The following is a description of a gene set: species: Homo sapiens Human Gene Set: HP_ABNORMAL_EAR_MORPHOLOGY Abnormal ear morphology Any structural anomaly of the ear., and this is the list of marker genes: DAW1, SEPTIN9, KIAA0586, DPH2, VPS53, CIT, CSPP1, PHIP, PIEZO1, FANCC (FA complementation group C), TCTN3, LONP1, TXNDC15, NOG, RSPRY1, TUBA1A (tubulin alpha 1a), GRHL3, NME5, SUPT16H, RAI1, GLRA2, RYR1 (ryanodine receptor 1), COLEC11, FLI1, NARS2 (asparaginyl-tRNA synthetase 2, mitochondrial), DCPS, TASP1, PDE6D, TENM3, GLI3, PTPN22, WDR35, CENPJ, ABHD5, NIPA1, NCF4, CAPRIN1, MGP, PROM1, KCNH1, WDR19, CTU2, EIF3F, GON7, TIMM8A (translocase of inner mitochondrial membrane 8A), GJB6, VSX1, TMEM147, JAG1, PLK4, GNB1, DPP6, STX1A, RMRP, RNASEH2B, TTI1, SMPD4, TOPORS, RPS23, KRIT1, KDM6A, GJB3, RDH11, CYBB, ALG6, ATP6V1B2, RBM10, GLIS3, MAX, KIF21A, GAS2L2, UHRF1, BRCA2, GAS8, KCNAB2, SYNGAP1, NKX2-1, KIAA0753, FOCAD, HSPG2, CDC45, MYH3, PDE6A, MPDZ, TMEM165, CERKL, ODAD4, ZMYM2, SMARCA4, MAN2B1, USB1, CEP55, MED27, MARS1, PIGS, SH2B1, ARID1B, CFAP298, ELANE, ADAMTS18, RPL5, TAP1, KATNIP, YWHAE, LRBA, NSUN6, TRAF7, VAC14, BSND, AIRE, HERC1, DSP, MSX1, TFAP2B, FGF20, DZIP1L, BBS12, PDCD1, H4C3, RIC1, SCARF2, XYLT2, POR, STT3A (STT3 oligosaccharyltransferase complex catalytic subunit A), TBCK, RIT1, AHR, SPIN4, NGLY1 (N-glycanase 1), PSMD12, ELN, PHGDH, SH3PXD2B, FTSJ1, FOXJ1, NDE1, RHOBTB2, DCLRE1C, SLC2A10, KIFBP, TAF1, ACTB (NCBI Gene Id 60), FIG4, B9D1, WWOX, TRIP11, DNAAF2, PDZD7, DDR2, TTN, USH1C, PIGY, PRDM16, SPEN, USH2A, CYP4F22, MRPS16, HNRNPK, INTS11, ARL13B, RPL35, MYOD1, TRIP13, MAB21L1, TMEM94, HECW2, DPYD, SLC32A1, IDS, DHCR24, CD81, PDPN, SPTBN1, NFKB2, CBLB (Cbl proto-oncogene B), EPG5, FOXL1, RPL18, B3GALNT2 (beta-1,3-N-acetylgalactosaminyltransferase 2), PDZD8, YRDC, DNAL1, RFWD3 (ring finger and WD repeat domain 3), TXNL4A, SNF8 (NCBI Gene Id 95670), EPAS1, ARX, PEX1, HDAC9, ZNF469, BBS2, GRB10, WLS, TGFBR1, PRKCD, GABRA3, PIGW, ZMYND11, DYRK1A, RIPPLY2, IMPG1, TALDO1, DEPDC5, PHF6, SETD5, NOTCH2NLC, ANK1, LIG4 (DNA ligase 4), RSPO2, CASP2, PLOD3, CTCF, ATR, NDST1, DPH1, UBA1, DNAI1, PHOX2B, FGF3, RAC1 (Rac family small GTPase 1), CRLF1, DNAAF1, ELMO2, SLC4A10, PCYT1A, DNAJC30, GLI2, TPP2, CPLANE1, SEMA4A, STK36, TCF4, COG7, TAFAZZIN, RSPH9, A2ML1, SMARCD2, EXTL3, KDM6B, KMT2B, MKS1, KCNK9, MCM5, GMNN, ACBD5, INSR (insulin receptor), RAG1, TMCO1, HEATR3, DDX6, CEP78, MGAT2, MBTPS2, EDNRA, SCLT1, SLC6A17, HLA-B, COL1A2, TOE1, ATIC, LMBRD2, KCNN3 (NCBI Gene Id 95947), AP1G1, TGM1, HCCS, NSD1, ORC4, SLC25A11, ASH1L, PIGK, CRELD1 (NCBI Gene Id 78987), RNF168, CHD7, SIX5, CCNQ, CHSY1, SYT2, PSMB8, ZSWIM6, SATB1, DHPS, CHD3, FBXO11, ZNF526, RET, SEC24C, ERF, BRD4, EGFR, FANCE, SLC7A14, LIPN, CENPF, GABRD, TRIO, SCN4A, CUL7, HMX1, SCNM1, CA4, EDEM3, CFAP300, SETBP1, SLC16A2, TBR1, GJB4, BPTF, KDSR, PPP1CB, FMR1, DNAI2, CHAMP1, SOST, MAFB, RAD51C, CD247, NCF2, IFT88, POLR1B, DCAF17, RUSC2, KLF13 (NCBI Gene Id 51621), GPKOW, PAX3, PYCR1, ZEB2, FSCN2, KIF11, BRAF, THOC1, ALG12, GTPBP2, SDHD, COG8, KIAA1549, FBXW11, AFF4, ZBTB20, IGHG2, DNAAF5, RAC2, TMEM138, CARMIL2, CBL, NALCN, HELLS, NPHP1, VPS35L, MUSK, PIK3CD, BTK, SLC37A4, BBS10, IGHM, TBX22, NEK2, SLC35C1, CASK, CCM2, DDX3X, SMAD2, CHUK, CSGALNACT1, POC1A, NFKB1, CLCF1, FANCD2, IFT56, CCDC103, SIAH1, RSPH1, TNFRSF13C, DPYSL5, RRAS2, PIGQ, RAB23, GUSB (glucuronidase beta), WDR37, DST, CEP290, GPT2, RPL9, KIF26A, NEXMIF, LMNA, STAMBP, RPL26, LRP5, BCOR, SKIC3, ECE1, DHCR7, FANCA, SLC25A12, SDHB, KAT8, PRTN3, B4GAT1, PDE6G, IL2RB, RAB11B, RPS24 (NCBI Gene Id 6229), IDUA, ACTG2, CCDC39, CDCA7, RPL31, TRPS1, CXCR4 (C-X-C motif chemokine receptor 4), ZNF668, RUNX2, TRPV6, NRCAM (NCBI Gene Id 4897), SOX9, HLA-DPA1, KCNJ10, FANCM, IDH3B, SEMA3E, MAD2L2, FRMPD4, UNC119, LBR, SH3KBP1, FOXP1, PRKCZ, PRORP, SPOP, FREM2, OCLN, LARGE1, ACAN, ABCA4, ORC1, RECQL, B3GALT6, DEAF1, ZNF513, TBCE, RARB, CSNK2A1, SPEF2, DRC1, AGA, FBN2, GAD1, POMT2, POMGNT1, AGPAT2, DNAH11, RERE, PI4KB, ANAPC7, RALGAPA1, PIK3CG, LRP2, VIPAS39, MAGT1, NR4A2, ITGA8, SRCAP, GATA1, EXOSC9, CEP295, H4C9, COL4A6, ACVR1, DOCK6, CDHR1, SPINT2, SPATA7, ANKRD11, LMX1B, EZH2, DLX5, HLA-DRB1, PLEC, OTUD7A, PAK3, TUB, AP1S2 (NCBI Gene Id 8905), RAB3GAP1, INPPL1, PLAG1, TMEM216, GDF11, SMOC1, TUBB, SLC6A8, MASP1, TPM2, ADGRG6 (adhesion G protein-coupled receptor G6), TRAC, KIF1B, MS4A1, SLC26A2 (solute carrier family 26 member 2), GUCA1B, UBE2T, PEX3, GNS, ZC4H2, SUOX, TUBGCP6, HDAC4, MAGEL2, OGT, ITGB4, SET, PSMC3, COCH (cochlin), ADAMTSL1, KLHL40, TRMT1, CDK13, AKT1, NR2E3, CCNO, UBA2, RPS27, CCDC65, SMC3, GRIA4, PEX10, PRKDC, CACNA1C, SIX2, FGFR1, SPART, FZD2, RFXAP, PORCN, UPF3B, ROR2, ADAMTSL2, CNOT2, TMEM70 (NCBI Gene Id 54968), ACOX1, CUX1 (cut like homeobox 1), FRMD4A, CFAP418, SBDS, EBF3, DOCK8, USP7, NEK9, TTC8, GREB1L, FRA10AC1 (NCBI Gene Id 57208), CCBE1, ETFA, BBS7, P4HA2, PCLO, ORC6, TP63, ARMC9, GNE, ITGA3, RPS15A, BLNK, TNFSF12, KDM5C, UBE3B, PREPL, ATP2B1, MCTP2, PPP1R15B (protein phosphatase 1 regulatory subunit 15B), MAK, UNC80, VPS37A, SDR9C7, MTHFR, AMMECR1, ALG13, MACF1, BMP1, IL21R, MRPS22, COL4A1, PNPLA6, TAF6, C1GALT1C1, HS6ST2, ATP6V1E1, ASCC3, SLC5A7, HYMAI, CAMKMT, NME8, POLR1D, DVL1, KCNQ1, KAT6A, BRCA1, ADAM17, NAA60, PRR12, BRIP1, MYO7A, ABCC1, HEPHL1, ALG9, RAB3GAP2, WAS, UBAP2L, PPM1B, HBA1, PRPS1, FCGR3A, PEX5, CD79B, JMJD1C, WAC, AGO2, ZNF423, EYA1, DIS3L2 (NCBI Gene Id 282696), BEST1, TBX15, POGZ, NOTCH2, CHRNG, TGDS, IRF6, WNT9B, WDR26, ANKH, CD79A, BMP4, PEX12, IMPDH1, BICRA, PRDM5, ANO1, KDM5A, SUZ12, ACP5, TBX4, RPS28, UMPS, SMC1A, DLK1, CD3G (NCBI Gene Id 917), RBM8A, STAG1, FOXP2, ETFDH, ESAM, MRPS2, MPLKIP, IDH1, AGBL5, POLR3A, PKHD1, CARS1, GJA1, DLG1, IGKC, PEX13, BBS1 (NCBI Gene Id 79702), ADA, HES7, EFEMP1, ARSG, MARS2, PRPF31, HDAC6, HS2ST1, RPS6KA3, RBP3, ZMYM3, EXT2, PSAT1, RPS29, RNU7-1, GTF2H5, PRKG2, CFAP221, KATNB1, RSPH4A, FOXF1, RP1L1 (RP1 like 1), NEB, APC2, PEX11B, PIGG, CDT1, DNAH9, MAD1L1, SOX6, PGM3, SLC1A4, ACTG1, SIN3A, EVC2, KCTD1, SULT2B1, MRAS, DHX16, TMEM237, CTH, PLAAT3, TWIST1, RPGR, FAM20C, MYO18B, PIGH, GLUL, IFT172, FAT4, AGRN, FBN1, DOCK2, CLCNKA, TMEM127, PRCD, POU4F1, STAC3, CPLX1, TNPO2, PDE6B, PIK3C2A, BMP2, CLTC, HSD17B4, GTF2IRD1, PLVAP, SGMS2, METTL27, CC2D2A, LIG1, KCNJ2, KDM5B, CCDC8, TBL2, RTL1, SPI1, RNASEH2A, EXOSC2, DHDDS, COL11A2, BRCC3, TNFRSF11A, B9D2, DACT1, IFIH1, H3-3A, SETD2, PTDSS1, RFXANK, VPS13B, CLCNKB, PLAGL1, TNNI2, RB1, RBBP8, ZBTB18, TLK2, SDHAF2, UBB, H4C5, SRRM2, NF2, IDH3A, RASA2, NEU1, CDK10, DBR1, LMBRD1, PPP2R5D, TTC12 (tetratricopeptide repeat domain 12), BICD2, TUBB3, SOX4, ODC1, CNGB1, SEMA5A, DOCK7, LRP4, CNOT3, RP9, JARID2, GJB2, BIN1, GJA8, TMEM260, INTS1, FKTN, CTNND1, RPGRIP1, SHOC2 (SHOC2 leucine rich repeat scaffold protein), RPS26, HUWE1, RAPSN, TCTN2, ZNHIT3, CAV1, SYK, RSPH3, BBS5 (NCBI Gene Id 428), CILK1, FUCA1, ODAD2, TBC1D20, PIBF1, CCDC50, MMP23B, NFIA, PUS7, LMNB1, NTNG2, TP73, OTUD6B (OTU deubiquitinase 6B), CLCN7, ALOX12B, TCF3, CDK5RAP2, PCDH15 (NCBI Gene Id 7397), UBR7 (NCBI Gene Id 55148), POLR1C, MAP3K7, RPS19, COBLL1, ICOSLG, CCDC22, NUP85, LETM1, ATP6AP2, ADAMTS15, STIM1, MLXIPL, PTEN, PPP1R12A, PCARE, YY1, MID2, LZTR1, ERCC1, QRICH1 (glutamine rich 1), SAMHD1, CDC42BPB, ACER3, SP7, OSGEP, COMT, PHACTR1 (NCBI Gene Id 81705), PLOD1, CFAP74, WARS2, PLAA, SF3B2, PLXNA1, RAB34, IL7R, COQ6, RREB1, NR2F1, TFAP2A, PEX2, CHMP1A, SCO2, YME1L1, RAP1B, CAMK2G, FKBP6, TRAPPC9, ELMOD3, EIF4H, SPECC1L, OTOF, PALB2 (NCBI Gene Id 79728), DHX38 (DEAH-box helicase 38), SALL1, GPX4, KMT2C, RRAS, TUBG1, MED25, PSMB10, DOK7, MYO9A, PGAP3 (post-GPI attachment to proteins phospholipase 3), PPP2R3C, FBLN5, SF3B4, CCDC47, RGR, DYNC2LI1, ESCO2, KIF14, FANCF, SMAD4, ROM1, HLA-DPB1, AARS1, COL2A1, MEGF8, IGF2, MEIS2, SHANK3, APC, FAR1, PAK1 (NCBI Gene Id 5058), SETD1A, SALL4, PAICS, NF1, ODAD1, CREBBP, GLE1, WIPF1, EFTUD2, LRPPRC, IL17RA, RELB, FKBP14, DENND5A, NAA10, RAF1, PCNT, AMPD2, TRRAP, FN1, RPS10, PNP, RELN, SLX4, ICOS, ARL2BP, MSX2, FANCG, IGBP1, TBC1D24, TUBGCP2, ATP6V0A2, BAZ1B, WNT3, TCOF1, CLRN1, MRPS14, CD3D, CEP120, GPC4 (NCBI Gene Id 2239), PLCH1, SON, PIK3R1, ODAD3, GDF6, MAP2K1, NIPBL, DNMT3A, ERCC5, PIGL, AGO1, TAPT1, CLIC2, PRPF6, MAP2K2, SATB2, TNFSF11, IKBKB, JUP, TNNT3, PUF60, NSDHL, RPL11, IL6ST, DNA2 (DNA replication helicase/nuclease 2), CD3E, CYBA, SSR4, G6PC3, MESP2, ABCC8, COL13A1, ESRP1, ERMARD, STRA6, TREX1, CEP57, DNAAF3, TBC1D23, CHD4, RLBP1, RNF2, VARS1 (valyl-tRNA synthetase 1), OPHN1, MVK, SDHC, CR2, PRRX1, MERTK (NCBI Gene Id 10461), THOC2, DNAAF4, ANTXR2, HGSNAT, JAK3, ARID2, AHDC1 (NCBI Gene Id 27245), POLE, SOS1, ZBTB24, SHARPIN, THRB (thyroid hormone receptor beta), TLR8, GNAI3, SIX1, U2AF2, WNK3, GLB1, SLC39A7, ASXL1, EXT1, ERCC8, PRPH2, FAM161A, GSC, TCF20, RTTN, LARP7 (La ribonucleoprotein 7, transcriptional regulator), USH1G, TBCD, TMEM231, POU3F3, SNAP29, RXYLT1, KMT2D, FDFT1, ATRX, LIFR, EXOC7, DNM1, SNAP25 (synaptosome associated protein 25), PDCD10, C2CD3, MEF2C, RPGRIP1L, GATA4, KIF15, MRPS28, VPS51, SNRNP200, EFEMP2, TOGARAM1, NANS, LAGE3, PLXND1, CACNA1B, OCRL, KDM4B (lysine demethylase 4B), PTPRF (protein tyrosine phosphatase receptor type F), CHD8 (chromodomain helicase DNA binding protein 8), TMEM270, TRIP12, ALX4, CEBPE, HHAT, THUMPD1, PLCG2, ITGB6, VHL, B4GALT7, PEX6, HMGA2, CDH2, MESD, CHST14, PRPF4, SCAPER, PIK3CA, SMCHD1, ERI1, SLC6A9, CHD5, ZMPSTE24, KAT6B, LSS, TBX2, KCNJ5, HARS1, AMER1, RDH12, CACNA2D1, UQCRH, KIZ, NHS, MECP2 (NCBI Gene Id 8274), VPS33B, CTBP1, TRAIP, MBD5, WARS1, AEBP1, FREM1, SAG, SLF2, MN1, KDM3B, CPE, AK2, CASZ1, GRIP1, DIAPH3 (diaphanous related formin 3), PUM1, CHRNA1, PGAP1, PAX1, DNAH1, TFE3, CDH11, HAX1, FOXI3, ARL3, TNRC6B, PITX1, AIP, ZNF699, NIPAL4, MRTFA, NUP188, SPAG1, WHRN, CIITA, CEP19, KLHL7, MSL3 (MSL complex subunit 3), SLC9A6, ROBO1, COX7B, HYAL1, ENPP1 (NCBI Gene Id 5167), CDKN1C, ZNF462, ATP6V1A, BSCL2, PIGU, NFKBIA (NCBI Gene Id 4792), PTF1A, EHMT1, BCL11A, RAD51, WNT4, IRX5, GPR101, SLC12A6, HAAO, EVC, MYSM1 (Myb like, SWIRM and MPN domains 1), TPRKB, TCTN1, DAG1, DNAJC21, USP26, IFT81, TTC5, HGD, ALX3, ZNF148, NFIX, SEC61A1, PCGF2, FGF9, B4GALT1, OSTM1, IFT52, ZFX, ATRIP, POLA1, IFT74, HRAS, ZMIZ1, SLC39A8, IREB2, LZTFL1, FBXW7, CAPN15 (calpain 15), NUP107, FH, IGLL1, FOXE1, RAG2, ARVCF, IGF1R, MCIDAS, CEP104, BUB1B, PIGO, AASS, ALMS1, ZDHHC9, ALDH1A2, NEK10, KNSTRN, HBA2, RFX5, C4B, NUP133, GRIA3, MED12, IPO8, SLC18A3, ERCC4, CLCN3 (NCBI Gene Id 133073), CTSD, FKRP, OTX2, WDR4, ESRRB, ADGRV1, CHRNA7, FRAS1, CDH23, IL2RG (NCBI Gene Id 3561), ARHGEF18, HOXA13, COL6A1, CTNND2, RAD21, BCL11B, STEEP1, ACTA1, WNT7A, TMEM67, CRB1, WBP11, RNASEH2C, PEPD, LFNG, ADAMTS3, STAT3 (signal transducer and activator of transcription 3), IFT140, BBS9, GFRA1, MDH2, WDPCP, PEX16, NRL, HIRA, TEFM, PIGV, NEK1, TCIRG1, CPOX, NECTIN1, DSE, SLC25A1, WDR73, SOD1, NKAP, CYBC1, KIF7, ALG2, SLC2A1, ADAR, IMPG2, CRPPA, DNAH5 (NCBI Gene Id 64774), ALDH18A1, UGP2, TP53RK, PQBP1, DPF2, FANCI, TTI2, SMS, RPL10, CENPE, PRKAR1B, AIFM1, LUZP1 (leucine zipper protein 1), WNT7B, MKKS, DHX37, CORO1A, PGAP2, ASXL2, KCNJ11, PEX14, RNU4-2, NIN, CCDC40, REEP6, TUBGCP4, ASPRV1, RPS7, CNTNAP2, ITGA6, DVL3, PBX1, COG5, PRPF8, TET3 (tet methylcytosine dioxygenase 3), C1QB, PAM16, FOXL2, ANAPC1, NARS1, HSPA9, AGR2, KMT5B, BBIP1, MMACHC, ASNS, MPDU1, RIPK4, LGI4, SRD5A3, DHX9, WBP4, DRG1, CTLA4, BAP1, FLII, LIMK1, MRPL12, PIGB (phosphatidylinositol glycan anchor biosynthesis class B), SRY, FGF10, RECQL4, TAF4, XRCC2, SDCCAG8, NUP88, PEX19, CD19, WNT5A, NAA80, CDH1, SNRPB, FOXN1, DDX11, XYLT1, PGM2L1, BMPER, METTL5, CNTNAP1 (contactin associated protein 1), FGFR2, NCF1, SIM1, ZIC3, HOXB1, RPS20, COL5A1, WASHC5, B3GLCT, ALG8, IL1RAPL1, CNGA1, PACS1, AFF3, ERLIN2, USP9X (NCBI Gene Id 8239), RALA, FBXL4, MT-TS2, PI4K2A, DLX4, SMG9, TSPEAR, ALG3, KCNK4, CCND1, SMARCA2, DNAJB13, SDHA, ESPN, BUB1, EEF1A2, MNS1, FOXI1, COLEC10, MAP1B, MAPK8IP3, FANCB, ATN1, KARS1, IFT122, WFS1, DHX30, AHSG, EYA4, AUTS2, AHI1, CNOT1, BLM, GTF2I, CD28, CFAP45, ADAT3, SLC3A1, ABCA12, RAP1GDS1, HDAC8, PAH, ERCC2, JAGN1, NSUN2, TGFB3, CREB3L1, CTSK, PAFAH1B1, HYDIN, PIGT, PRUNE1, TNFRSF13B, VANGL2, PIEZO2, ZNF341, NBN, H19, SMARCD1, PIGN, TSHZ1, EP300, DNMT3B, DLST, TULP1, B3GAT3, SMG8, CLIP2, RRAGC, KAT5, CUL4B, CD4, INTU, CCDC32, IFT27, GPRASP2, CCNK, PLG, PPP1R21, EMC1, LRRC8A, SOX5, RP2, EIF5A, COL11A1, CFAP52, DCHS1, EFL1, BHLHA9, RPL35A, NSRP1, PRDX1, MAPRE2, VAMP1, USP48, COL1A1, RPL15, HMGB3, FIBP, RPL27, RPS17, OFD1, BRWD3, EIF2S3 (NCBI Gene Id 8422), TELO2, TRIM32, RPL8, NIPA2, SUFU, IL11RA, DDX59, DNAAF11, CD96 (CD96 molecule), LRRC56, DONSON, RBMX, CAMTA1, LMOD3, PURA, COG3, CIB2, DLL3, NEUROG1, NXN, GBA1, PEX26, SCYL2, TBL1XR1, CBY1, TOR1A, C12orf57, CHRND, SNX10, AFF2, SMC5, ARL6, MAF, POMK, UBE2A, ARHGAP29, ETFB, VPS37D, ZNF711, CDC6, ERBB3, DHODH, TARS1, RNF113A (ring finger protein 113A), GNB2, PYCR2, EED, CFI, RAB5IF, HOXD13, NAA20, MAN2C1, KCNQ1OT1, MED13L, SPEG, ARHGEF38, BUD23, DPP9, SPRED2, TMEM218, RAB18 (RAB18, member RAS oncogene family), SLC26A4, FOXG1, FLNA, HOXA2, MAN1B1, ERCC3, NELFA, WASHC4, IL6R, RPE65, ABCC6, PTCH1, CHST3, PCDHGC4, NOTCH3, EIF4A2, EBP, KRAS (NCBI Gene Id 3845), ERCC6, ITCH, CEP152, RNU4ATAC, KANSL1, UBE4B, BBS4, LAS1L, PAX7, SPRED1, CACNA1G, CRKL, PGM1, FGFR3, FGD1, GATA2, SLC25A24, AP3B1, SLC12A2, EDN1, ZNF292, FHL1, PRIM1, AP3D1, ADNP, IRF2BP2, MITF, EIF4A3, TRMT10A, ASXL3, EYS, FAM149B1, GALNT2, PTH1R, GJA5, KMT2A, CHN1, OTUD5, GNPTAB, ADA2 (adenosine deaminase 2), ZNF408, MYCN, SKI, FANCL, IKBKG, ALX1, TAOK1, TRPV4, CAMK2A, PDE4D, COL3A1, ARID1A, TBX1, BMPR1A, SOX10, SOS2, UFC1, NRAS, FLNB, PDGFRA, ADAMTS2, EXOC2, CRX, SYNE1, MINPP1, NCKAP1L, GK, BLTP1, PMM2, COL7A1, BCR, NSD2, ZMYND10, ANTXR1, RFX7, CHAT, SOX11, MEG3, GPC3, NDP, TWIST2, POMGNT2 (protein O-linked mannose N-acetylglucosaminyltransferase 2 (beta 1,4-), NCBI Gene Id 84892), TSR2, DNAAF6 (NCBI Gene Id 139212), CANT1, POU3F4, HECTD4, MYMX, GTF2E2, GP1BB, PLCB4, DDB1, BUB3, ALKBH8, PIGA, UGDH, GPC6, KCNJ1, CWC27, TPM3 (NCBI Gene Id 91191), UFD1, TMEM107, COG1, HIVEP2, POLR1A, FGFRL1, NDUFB11, CDC42 (cell division cycle 42), ARSL, AP4E1, PPM1D, MID1 (midline 1), LRAT, ZNF407, GTF2IRD2, POMT1, BRPF1, QARS1, RFC2, STAG2, KYNU, CEP41, SMARCB1, BRF1, INPP5E, ZIC2, MBTPS1, MADD, LSM11, KLHL41, ADSL, DOCK11, MAPK1, HYLS1, OBSL1, RP1, ALOXE3, STXBP1, IQSEC2 (NCBI Gene Id 4382), CPT2, CA2, MEOX1, GDF5, RHO, CCN2, PTPN11, HNRNPH1, PRPF3